The following is a description of a gene set: Erythropoietin activates Phospholipase C gamma (PLCG) Human Gene Set: REACTOME_ERYTHROPOIETIN_ACTIVATES_PHOSPHOLIPASE_C_GAMMA_PLCG studied in species Homo sapiens, and this is the list of marker genes: PLCG2, LYN, JAK2, EPO, EPOR, PLCG1, IRS2